Given this list of marker genes Scp2, Plcg2, Lhcgr, P2ry1, Pou1f1, Myh9, Gper1, Plcg1, P2ry6, Ptafr, Plcd1, here is a description of the gene set: species: Mus musculus The chemical reactions and pathways resulting in the formation of inositol trisphosphate, 1,2,3,4,5,6-cyclohexanehexol, with three phosphate groups attached. Mouse Gene Set: GOBP_INOSITOL_TRISPHOSPHATE_BIOSYNTHETIC_PROCESS